The following is a description of a gene set: Mouse Gene Set: GOBP_NEGATIVE_REGULATION_OF_TRANSCRIPTION_BY_RNA_POLYMERASE_II studied in species Mus musculus Any process that stops, prevents, or reduces the frequency, rate or extent of transcription mediated by RNA polymerase II., and this is the list of marker genes: Nkx3-1, Psmd10, Pax5, Ogt, Bcorl1, Gadd45a, Otud7b, Magel2 (MAGE family member L2), Nkx2-5, Cnot2, Men1, Pou3f1, Zbtb18, Zfp3, Il1b, Dkk1, Jun, Epas1, H3c14, Esr2, Mbd3, Pou4f2 (POU domain, class 4, transcription factor 2), Cul3, Ifi27, Mkx, Zfp296, Tmbim6, Ptch1, Scgb1a1, Isl1, Hjv, Raly, Nr2e1, Dnajc17, Nfkb1, Mnt, Olig2 (NCBI Gene Id 50913), Mageb6b1, Sp3, Hoxd8, Fezf2, Crebrf, Magea1 (MAGE family member A1), Bmyc, Zfp469, Magea9, Sqstm1, Twist1, Lrrfip1, Sox21, Pole3, Wwc1, Mdm2, Amotl2, Atf7, Zbtb33, Pou3f3, Hdac3, Klf5, Tbx18, Snai2, Skor1, Dnmt1, Sap130, Ins2, Mapk15, Jph2, Brms1l, Ift172, Ylpm1, Cbx6, Bend3, Ddx20, Zfp750 (zinc finger protein 750), Irf2bp2, Zfp819, Nepn, Sirt2, Rbm10, Supt5, Zbtb26, Strn3, Eno1b, Hba-x, Ppara, Satb1, Zbtb10, Snai3, Snw1, Cd36, Irx3, Tcp10b, Nog, Tmprss6, Sox3, Msx1, Cnbp, Foxp2, Zfp746, Ifi213, Hdac9, Ralgapa1, Zfp354a, Med1, Mzf1, Brms1, Mettl13, Dcaf1, Sla2, Cbx7, Myocd, Mnx1, Nedd4, Zbtb39, Pax2, Kcnip3, Zfp281, Gli2, Id1, Phf6, Sdcbp, Mta3 (metastasis associated 3), Klf16, Dicer1, Dusp26, Larp7, Id3, Cbx8, Msx2, Trim27, Olig3, Timeless, Sarnp, Smyd2, Nrarp, Amot, Tbx21, Tpr, Mlx, Hes7 (NCBI Gene Id 84653), Hbp1 (NCBI Gene Id 77235), Nop53, Zfp148, Elk3, Dlg1, Chd5, Irx1, Ezh2, Foxk2 (NCBI Gene Id 76149), Atf7ip, Sars1, Thap11, Fasl, Smad3, Rpl10-ps3, Ccne1, Tcp10a, Trpv4, Trim37, H1f5, Ascl5, Bhlhe41, Lin37, Txnip, Sox1, Ctbp1, Zc3h8, Tbx22 (T-box 22), Fbln5, Ifng, Dnaja3, Ppp1r15a, Tbx20 (NCBI Gene Id 77243), Zfp90, Helt, Cry2, Mepce, Sox14, Mynn, Mitf, Mdfi, Mael, Zbed6, Prdm14, Mxd4, Mbd3l2, Pkig, Nif3l1, Cbx2, Sema4d, Myoz1, Zhx2, Notch1, Ascl1, Prmt5, Esx1, Coq7, Notch2, Dll4, E2f1, Hipk1, Tagln3, Ifi214, Foxm1, Shh, Thra (NCBI Gene Id 319227), Tet1, Nfil3, Ctcf, Pax6, Dmrt1, Med25, Tgif1, Zfp239, Gli3, Zfp366, Foxp4, Samd11, Zfp128 (zinc finger protein 128), Hopx, Foxa2, Zfp131 (zinc finger protein 131), Tle1, Gata1, Dlx4, Mafk, Pawr, Bach2, Prdm1, Nfe2l1, Sall4, Psen1, Magee1, Mypop, Magea13, Smo, Ndn, Nfic (NCBI Gene Id 69000), Hmg20a, Mbd2 (methyl-CpG binding domain protein 2), Smad7, Nr1i2 (nuclear receptor subfamily 1, group I, member 2), Halr1, Zeb1, Suv39h2, Lep, Cir1, Ctnnb1, Foxa1, Foxp1, Heyl, Cbfa2t2, Nkx6-2, Jarid2, Dmbx1, Calr, Gtf2ird1, Ikzf1, Ascl3, Wdtc1, Tbx2, Runx1, Srebf2, Zfp263, Magea5, Dnajb5, Hexim2, Arid4b, Ptpn2, Hand1, Slfn1, Cry1, Cbfb, Ybx1, Flcn, Atn1, Mxi1, Mtdh, Eid2 (NCBI Gene Id 386655), Taf9b, Nkx6-1, Msx3, Rxra, Nfix, Zbtb2, Atf3, Rreb1, Tnfsf11, Dusp22, Wwtr1, Nr4a2, Zfp568, Suds3, Glis2, Sox10, Pou4f1, Cbx4, Xbp1, Foxs1, Spen, Pcgf6, Mcph1, Gata2, Vdr, Chd8, Magea10, Fam220a, Sap30, Scrt1, Flywch1, Hey2, Sry, Zbtb20, Hesx1, Cxxc5, Macroh2a2, Ahrr, Il4, Zfp217, Mageb5, Hnrnpk, Pcna, Hes1, Zbtb42, Nr2f6, Impact, Macroh2a1, Wnt10b, Morc3, Wdr5, Wfs1, Skor2, Srebf1, Prkn, Fnip1, Hmgn2, Hnrnpab, Tenm2, Glis1, Scaf4, Hdac10, Il33, Cebpb, Sp100, Met, Pax4, Zfp715, Trp63, Per1, Tdg, Gfi1, Klf2, Prrx1, Sirt1, Nfatc1 (NCBI Gene Id 72364), Trim28, Ctr9, Samd1, Zhx1, Ppp1r13l, E4f1 (NCBI Gene Id 13560), Isx, Hes6, Rbm15, Cic, Stat1, Prmt6, E2f8, Thap1, Phf12, Rhox5, Tle5, Fbp1, Rfx5, Nr1h4, Zbtb34, Hoxb13, Dr1, Ncor2, Supt4a, Rbbp4, Nr1d2 (NCBI Gene Id 353187), Insm1, Barx2, Hdac1, Khdrbs1, Hexim1, Tbx1, Cnot1, Rtf1, Rlim, Zbtb25, Mndal, Nr2c2, Mta2, Esr1, Ciita, Tbl1x, Spop, Notch3, Tfap2b, Smad5, Zfp13, Apbb2, Dubr, Wt1, Elane, Taf7, Smad4, App, Hbb-bh1, Edn1, Klf12, Zfp451, Foxc1, Nck1, Ednrb, Hoxd9, Myt1l, Nipbl, Bmi1, Foxg1, Zfpm1, Hsf4, Klf8, Nr3c1, Maz, Acvr2b (activin receptor IIB), Bcl6, Irx2, Hic1, Hmga1, Tgfb1, 5730507C01Rik, Mlxipl, Bcor, C1qbp (NCBI Gene Id 28127), Sall2, Zfp973, Samd7, Smarcc2, Znhit1, Gata6 (NCBI Gene Id 14465), Foxe1, Nr1h3, Efna1, Hcls1, Hmx1, Fezf1, Otp, Akirin2, Sox9, Sirt7, Cela1, Hmbox1, Etv6, Kat2b, Prdm16, Foxl2, Zfp653, Hipk2, Yap1, Sox30, Apbb1, Nr1h5, Mef2a, Uri1, Lpin1, H1f3, Nr2f1 (NCBI Gene Id 13865), Zbtb14, Twist2, Kank2, Sin3a, Trps1, Pcbp3, Nr0b1, Ripply2, Snai1, Ovol2, Apbb3, Mageb18, Ankrd2, Lmo1, Mageb2, Nupr2, Prdm6, Ybx3, Hinfp, Atxn1l, Map2k5, Ifi209, Tle4, Hey1, Etv3, Zfp382, Ifi207, Pura, Ezr, Hcfc1, Sox8, Gata3, Aurkb, Irf2bp1, Cux1, Epc1, Dnajb4, Nfx1, Kat14, Kat5, Gatad2b, Ptgs2os (NCBI Gene Id 639611), Cited2, Larp7-ps, Osr2, Ing1, Foxo1, Nacc2, Gata5, Arid4a, Ddx5, Dab2ip, Traf6, Tcf23, Supt4b, Hmga2, Ptprc, Zfp174, Zbtb7a, Irf8, Ets2, Tfcp2l1, Zbtb32, Sox15, Sik1, Zfp202, Ncor1, T, Sorbs3, Nkx2-1, Zfp748 (zinc finger protein 748), Jazf1, Esrra, Pou5f1, Tada3, Tsc22d4, Zbtb21, Usp3 (NCBI Gene Id 235441), Sinhcaf, Setdb1, Nr0b2, Maged1, Spdef, Arid1a, Hoxc8, Bptf, Zmynd8, Hoxb3, Pcgf2, Mospd1, Lyar, Pias1, Tbl1xr1, Nr1i3, Sap30l, Nck2, Cdx4, Dact1, Foxq1, Ehmt1, Pitx2, Hivep1, Magea2, Msc, Lcor (NCBI Gene Id 73153), Neurog3, Rest, Sirt6, Nkx3-2, Kdm5a, Rsl1, Mageh1, Crem, Gsc, Igf2, Prkaca, Fgfr1, E2f7, Parp9, Epo, Zfp683, Zglp1, Hdgf, Traf7, Zgpat, Eed, Ehmt2, E2f6, Mad2l2, H1f4, Drd3, Ep300, Sdr16c5, Sp2, Nscme3l, Paf1, Rnf2, Maged2, Fgfr2, Ppard, Satb2, Zfp219, Ppid, Rarg, Sfpq, Mbd3l1, Plk3, Mir7-1, Kdm1a, Sox2, Ifi203-ps, Rbpj, Hipk3 (homeodomain interacting protein kinase 3), Shox2, Zbtb37, Ddit3, Zfp1006, Dnajb1, Nfib, Rpl23, Nelfe, Ankrd1, Hnrnpa2b1, Cc2d1a, Bmp6, Per3, Tcp10c, Cggbp1, Vegfa, Tle6 (NCBI Gene Id 69799), Tsix, Trib3, Gabpa, Nr6a1, Pou6f1, Vax2, Irx4, Ripply1, Myc, Tro, Magec2, Nr2f2, Pou1f1, Rps14, Yeats2, Foxr1, Rybp, Six1, Wwp2, Mageb3 (MAGE family member B3), Parp1, Zfpm2, Prox1, Kmt5a, Rfc1, Maf, Zbtb8a, Hnf1b, Cdk6, Tnf, Gatad2a, Fgf9, Klf11, Hdac7, Fhl2, Mef2c, Eng, Ahr, Nsmce3, Pax3, Frk, Dab2, Zfp57, Mdm4, Atf2, Trpv1, Zbtb16 (NCBI Gene Id 235320), Osr1, Arx, Noc2l, Tcf7l2, Magea3, Zbtb49, Hdac5, Foxp3, Hbb-y, Sall1, Klf7, Zfp608, Tcf21, Zfp692, Chd3, Ezh1, Sox13, Dmap1, Prnp, Ovol1, Rarb (retinoic acid receptor, beta), Phf14, Klf4, Atxn1, Tfap2a, Zbtb7b, Vax1, Egr1, Hdac2, Foxf1, Klf17, Nr1h2, Sfn, Foxj1, Deaf1, Sox4, Ferd3l, Lmcd1, Nsd2, Aebp1, Drap1, Jund (NCBI Gene Id 16478), Zbtb12, Prdm12, Hnrnpu, En1, Usp2, Nrip1, Batf3, Glis3, Foxc2, Hoxa2, Phf21a (NCBI Gene Id 399586), Mageb4, Traf3ip1 (TRAF3 interacting protein 1), Magea14, Rela, Pcgf1 (NCBI Gene Id 69837), Rb1, Cbx5, Zbtb24, Tbx15, Kdm2b, Eid1, Zfp958, Sgf29, Cops2, Ikzf5, Pias3, Tal1, Nrip2, Dach1, Trp53, Fgfr3, Pkia, Ajuba, Foxo3, Suz12, Nfatc2, Hes2, Phb1, Bhlhe40, Nr4a3, Cebpa, Tgif2, Magea4, Kdm5c, Atf4, Sox12, Yy1, Suv39h1, Cdx2, Cpeb3, Pde2a, Tsg101, Id2, Rhox2a, Hdac4, Ccnd1, Mapk10, Zbtb4, Peg3, Dusp15, Nfe2l3 (NCBI Gene Id 18025), Max, Nr2e3, Cdkn1c, Keap1, Taf3, Sox18, Hamp, Cdk2 (NCBI Gene Id 353061), Pias4, Skil, Alx1, Id4, Mageb11, Ccnd3, Nsd1, Mmp12, Vhl, Dlx1, Mbd1, Foxd3, Spi1, Per2, Rbbp7, Zfp354c, Wwc2, Arid5a, Runx3, Hoxb4, Ripply3, Irf2bpl, Hoxa7, Pdx1, Insm2, Gbp4, Prdm2, Ldb2, Thap7, Ski (NCBI Gene Id 99956), Cav1, Mier3, St18, Irx6, Ncoa2, Mier2, Dnmt3b, Trim29, Src, Hif1a, Uhrf1, Hmgb1, Cux2, Tbx3, Cdc73, Nkx6-3, Zfp386, Arid5b, Lmo4, Smarca4, Mxd3, Elk4, Patz1, Ctnnbip1, Rif1, Scrt2, Cbfa2t3, Zfp354b, Zfp473, Gm4924, Myoz2, Cc2d1b, Foxh1, Hhex, Mxd1, Ascl2, Mlip, Notch4, Nodal, Ifi206, Tcf3, Fnip2, Bach1, Hspa1a (NCBI Gene Id 193740), Klf3, Jdp2 (Jun dimerization protein 2), Xpo1, Dlx2, Nkap, Mta1, Nfkbia, Myef2, Eomes, Tcf25, Rara, Mbip, Tcerg1, Zbtb1 (zinc finger and BTB domain containing 1), Eno1, Zeb2, Hes5, Hes3, H1f2, Tfec, Rhox3a, Scaf8, Crebbp (NCBI Gene Id 547230), Ifi208, Pparg, Plk1 (NCBI Gene Id 18817), Magea6, Thrb, Mecp2, Ifi203, Hmgb2, Kat2a, Zmym5, Strap, Gata4, Psen2, Zfp932, Hoxb8, Chd4, Bmp2, Nr1d1, Rbl1, Zfp175, Prdm5, Aebp2, Hsf1, Glrp1, Tcf4, Sp5, Tcf7, Tbx6, Rpl10, Nr2c1, Lef1, Bcl11a, Gm4275, Nanog, Sin3b, Zfhx3, Rorc, Sox6, Zbtb45, Gps2, Foxk1, Ldb1, Bin1, Zbtb6, Ar (NCBI Gene Id 11835), Fst, Zfp36, Phf19, Zbtb5, Sim2, Uxt, S100a1, Zbtb46, Daxx, Magee2, Myb, Txn1, Sox11, Asxl2, Lefty1, Purb, Sufu, Ing2, Loxl2, Mageb5b, Crym, Mier1, Ighmbp2, Bmp4, Stat6, Hnf1a, Mageb16 (MAGE family member B16), Nfatc4, Prop1, Gzf1, Zfp668, Ube2i, Dnmt3a, Btg2, N4bp2l2, Zfp536, Hcfc2 (NCBI Gene Id 67933), Bcl6b, Vsx2, Magea8, Tcfl5, Prdm13, Ywhaz, Npas1